The following is a description of a gene set: Mouse Gene Set: GOBP_MUSCULAR_SEPTUM_MORPHOGENESIS The process in which the muscular septum is generated and organized. The muscular septum is the lower part of the ventricular septum. species: Mus musculus, and this is the list of marker genes: Bmp4, Tgfbr3, Fzd2, Fzd1, Vangl2, Hey2